Given this list of marker genes Gapdh-ps15, Crb2, Gapdh, Nlrp2, Sorl1, Prnp, Gapdhrt, Bin1, Wfdc2, Gapdhrt2, here is a description of the gene set: species: Mus musculus Mouse Gene Set: GOMF_ASPARTIC_TYPE_ENDOPEPTIDASE_INHIBITOR_ACTIVITY Binds to and stops, prevents or reduces the activity of aspartic-type endopeptidases.